Given this list of marker genes Tgfb1, Ppbp, Ccl19-ps5, Gm13277, Tgfb2, Bmp8a, Il24, Thpo, Tnfsf13, Gdf3, Vegfa (vascular endothelial growth factor A), Wnt1, Pf4, Tnfsf10, Il4, Cxcl15, Pglyrp1, Ccl9, Ifnk, Cxcl1, Ebi3, Wnt8b, Wnt5a, Ccl19-ps1, Il12a, Cxcl11, Gpr15lg, Fasl, Ccl3, Wnt8a, Cmtm5, Wnt6, Wnt10b, Ccl6, Il17f, Ccl26, Il36a, Tnfsf13b, Wnt7b, Bmp2, Mstn, Bmp7, Csf2, Ifna6, Xcl1, Bmp15, Ifnl2, Gdf5, Il27, Inhba, Il17b, C1qtnf4, Tnfsf12, Ifna5, Il17c, Cxcl5, Ccl21e, Ctf2, Inhbe, Crlf1, Il7, Tnf, Csf1, Gpi1, Gh, Il25, Ifna2, Ifna15, Ccl5, Slurp1, Cxcl2, Bmp5, Bmp1, Ccl27a, Lefty2, Il16, Gdf15, Prl7d1, Bmp6, Ifna14, Il33, Wnt5b, Gm13271, Il21, Cxcl14, Ifna12, Il1f10, Ccl19-ps6, Wnt3a, Tnfsf9, Ccl1, Il18, Il17a, Fam3b, Ccl21f, Il19, Cmtm2b, Nampt, Ifng (interferon gamma), Lif (leukemia inhibitory factor), Il20, Wnt10a, Il1rn, Gm13276, Ccl25, Tnfsf11, Tnfsf18, Ifna9, Ltb, Il36b, Gdf2, Tnfsf8, Ccl7, Gdf10, Il2, Cmtm2a, Wnt3, Flt3l, Wnt2, Cmtm7, Alkal2, Ifna7, Il15, 6030468B19Rik, Ccl19-ps4, Ccl19, Wnt11 (wingless-type MMTV integration site family, member 11), Mif, Ifnab, Cmtm8, Il22, Gdf6 (NCBI Gene Id 242316), Ifna4, Scg2, Grem2, Gdf9, Il6, Ccl19-ps3, Ifna1, Sectm1a, Ctf1, Il10, Crlf2, Cxcl13, Il13, Ccl17, Ccl22, Cxcl16, Wnt16, Il36g, Gm13283, Gm13272, Ccl24, Bmp4, Il17d, Grem1, Wnt4, Scgb3a1, Tafa5, Ifna13, Cxcl3, Wnt2b (NCBI Gene Id 22414), Fgf2, Il31 (NCBI Gene Id 76399), Ifnb1, Epo, Tnfsf4, Ccl11, Lefty1, Il23a, Inhbc, Ccl12, Eda, Ifna16, Cmtm3, Alkal1, Il9, Msmp, Il1a, Gm13275, Gdf7, Gdf1, Tnfsf14, Areg, Spp1, Osm, Tslp, Ccl28, Bmp10 (bone morphogenetic protein 10), Ifna11, Cx3cl1, Il1b, Cxcl10 (C-X-C motif chemokine ligand 10), Inhbb, Bmp3, Cxcl12, Ccl21b, Ccl20, Bmp8b, Timp1, Wnt9a, Il36rn, Cntf, Il11, Kitl, Ifnl3, Cklf, Nodal, Grn, Cxcl17, Cxcl9, Tnfsf15, Ccl4, Il22b, Wnt7a, Cer1, Hmgb1, Ccl8, Ccl2, Ifnz, Ccl21a, Tgfb3, Csf3, Aimp1 (NCBI Gene Id 320948), Edn1, Sectm1b, Ndp, Cd40lg, Lta, Il5, Clcf1, Il3, Fam3c, Ccl21d, Ifne, Il34, Inha, Gdf11, Wnt9b, Il12b, here is a description of the gene set: species: Mus musculus The activity of a soluble extracellular gene product that interacts with a receptor to effect a change in the activity of the receptor to control the survival, growth, differentiation and effector function of tissues and cells. Mouse Gene Set: GOMF_CYTOKINE_ACTIVITY